Given this list of marker genes TWF1, PRELP, MYD88, PTPRK, INPP1, TCF7L2, PCDH1 (NCBI Gene Id 5097), ATP6V0B, IGF1, EFNB3, RBM3, GGA3, PCNA, KIFC1, IRF2, PSG1, NMT1, C3AR1, CDC25A, IFNGR1, TFPI2, RIN2, PRMT1, AKAP6 (A-kinase anchoring protein 6), SEMA4D, PPP2CB, TOPBP1, LRP1, RAB7A, IL1R1, MTA1, TLE1, DUSP5, PTPRN2, ITGAL (NCBI Gene Id 3683), TCEA2, PCYT2, BTG3, HNMT (histamine N-methyltransferase), BAP1, RBM5, POFUT1, KCNK1, SLC9A6, ARNT2, SLC35B1 (solute carrier family 35 member B1), SERPINB2, ITGB1, RAP2A, MIR9-1HG, HNRNPD, RAB9A, PAFAH1B3, IL18R1, TGFB3, ADAM11, KRT13, SUOX, SLC31A2, PRKAB1, here is a description of the gene set: Human Gene Set: KYNG_DNA_DAMAGE_BY_4NQO_OR_UV species: Homo sapiens The accumulation of DNA damage and mutations is considered a major cause of cancer and aging. While it is known that DNA damage can affect changes in gene expression, transcriptional regulation after DNA damage is poorly understood. We characterized the expression of genes in human primary fibroblasts after exposure to three different kinds of cellular stress that introduces DNA damage: 4-nitroquinoline-1-oxide (4NQO), gamma-irradiation, or UV-irradiation. Each type of stress elicited damage specific gene expression changes of up to 10-fold. A total of genes had similar changes in expression of 3-40-fold after all three kinds of stress. We examined transcription in cells from young and old individuals and from patients with Werner syndrome (WS), a segmental progeroid condition with a high incidence of cancer, and found various age-associated transcriptional changes depending upon the type of cellular stress. Compared to young individuals, both WS and old individuals had similarly aberrant transcriptional responses to gamma- and UV-irradiation, suggesting a role for Werner protein in stress-induced gene expression. Our results suggest that aberrant DNA damage-induced gene regulation may contribute to the aging process and the premature aging in WS from publication Kyng KJ, May A, Stevnsner T, Becker KG, Kølvrå S, Bohr VA (PMID 15897889) 4NQO treatment and UV irradiation responding genes.